The following is a description of a gene set: Binding to a long-chain fatty acid. A long-chain fatty acid has an aliphatic tail containing 13 to 22 carbons. species: Mus musculus Mouse Gene Set: GOMF_LONG_CHAIN_FATTY_ACID_BINDING, and this is the list of marker genes: Cyp4f14, Fabp9, Ppard, Tmem175, Fabp4, Rida, Fabp3 (fatty acid binding protein 3, muscle and heart), Cd36, Pitpna, Fabp1, Cyp4a14, Scp2, Prr7, Hnf4a, Ucp1, Snca, Stx3, Fabp2, Pparg, Gpr31b, Alox5ap